Given this list of marker genes PIAS1, MX1, IFNAR2, IRF1, TYK2, IRF9, STAT1, MED14, TAP1, IFNAR1, OAS1 (2'-5'-oligoadenylate synthetase 1), JAK1, JAK2, IFI35, PSMB8, IFIT1 (interferon induced protein with tetratricopeptide repeats 1), IFNGR1, IFIT3, STAT2, PTPN2, IFITM1, IFNGR2, SOCS1, here is a description of the gene set: Human Gene Set: WP_IMMUNE_RESPONSE_TO_TUBERCULOSIS studied in species Homo sapiens Immune response to tuberculosis